Given this list of marker genes Sesn1, Cdkn1a, Casp3, Mdm4, Bbc3, Ccne2, Cycs, Trp53, Ccnb1-ps, Ppm1d, Cdk1, Pten, Rrm2, Ccnd3, Ddb2, Tsc2, Zmat3, Bid, Cd82, Shisa5, Rchy1, Mdm2, Adgrb1, Pmaip1, Ccnb1, Chek2, Pidd1, Ccnb3, Cdkn2a, Siah1b, Gadd45g, Chek1, Ccng2, Ccnd1, Atr, Fas, Rprm, Bax, Ei24, Cop1, Siah1a, Gadd45a, Cyct, Gtse1, Trp73, Ccne1, Ccng1, Rrm2b, Casp8, Perp, Cdk6, Cdk2, Apaf1, Casp9, Thbs1, Igfbp3, Steap3, Gadd45b, Ccnd2, Serpine1, Sesn2, Serpinb5, Igf1, Sfn, Ccnb2, Atm, Sesn3, here is a description of the gene set: studied in species Mus musculus Mouse Gene Set: WP_P53_SIGNALING p53 signaling